The following is a description of a gene set: Human Gene Set: WP_SELECTIVE_EXPRESSION_OF_CHEMOKINE_RECEPTORS_DURING_TCELL_POLARIZATION Selective expression of chemokine receptors during T-cell polarization studied in species Homo sapiens, and this is the list of marker genes: CXCR3, IL4, TGFB2, IL5, CD28, TGFB3, CCR3, TGFB1, CCR2, CXCR4, IL12A, CCR4, IFNGR2, IL18R1, CCR1, IL12RB1, IL4R, CCR7, CD4, CCL3, CCR5, CCL4, IL2, CSF2, IL12B (interleukin 12B), CD40LG (CD40 ligand), IL12RB2, IFNGR1, IFNG